The following is a description of a gene set: Unilateral primary pulmonary dysgenesis species: Homo sapiens Human Gene Set: HP_UNILATERAL_PRIMARY_PULMONARY_DYSGENESIS, and this is the list of marker genes: DGCR6, TBX1, ESS2, DGCR8, DGCR2